Given this list of marker genes ESYT2, NOL8, PTGES3, MAF, UBE2B, PRLHR, HLTF, CTH, HOXC10, ZNF75D, FRMPD3, ARMCX5, MYD88, EPGN, CDH1, RBFOX1 (NCBI Gene Id 54715), SLC35G3, CDH11, ZNF518B, VPS33A, AGTPBP1 (ATP/GTP binding carboxypeptidase 1), THOC2, ADGRF1, NOP9, COLQ, ZNF776, TAFA5, DOP1A, ADCY5, HTR3E (5-hydroxytryptamine receptor 3E), FAHD2B, ST8SIA2, IL7R, SERPINB1, GMNC, ZNF410, PPP2R5E, ALDH6A1 (aldehyde dehydrogenase 6 family member A1), C14orf28, OR7D2, LDB2, SPMIP6, CASTOR2, DOCK9 (dedicator of cytokinesis 9), ACVR1B, COL4A6, EXOG, FNIP1, DBH, PACC1, WAPL, POT1 (protection of telomeres 1), PRKAB1 (protein kinase AMP-activated non-catalytic subunit beta 1), GRIA4, GNAQ, DNM1L, ZNF483, C7 (complement component 7), DPCD, KATNAL1, CCDC51, ASXL3, ACOX1, SDC3, MFAP3, C17orf75, HPSE, FANCD2, VLDLR, GPM6A, here is a description of the gene set: species: Homo sapiens Human Gene Set: MIR510_5P from publication Chen Y, Wang X (PMID 31504780) Genes predicted to be targets of miRBase v22 microRNA hsa-miR-510-5p in miRDB v6.0 with MirTarget v4 prediction scores > 80 (high confidence targets).